Given this list of marker genes Git1, Grin3a, Ppp1r13l, Ahr (aryl-hydrocarbon receptor), Mir7578, Angpt2, Nbl1, Foxp3, Inpp5f, Pcbp2, Sh2d1b1, Igf1, Sh2d1b2, Wnt5a, Cers2, Ilrun, Clec12a, Il4, Mvk, Stat3, Fpr-rs7, Slit1, Plxna3, Clec12b, Ifi209, Rtn4rl1, Tyro3, Cask, Stap1, Trib1, Serpinb9e, Mir147, Phldb2, Gstp1, Eif4e2, Cacnb3, C5ar2, Lgals9, Ctnna2, Irgm1, Tnfaip3 (tumor necrosis factor, alpha-induced protein 3), Hamp, Spn, Ifi206, Siglecg, Grid2, Nfkbil1, Inpp5d, Rtn4r, Drd4, Adtrp, Nr1d2, Ythdf3, Fam3a, Ifi203-ps, Ier3, Robo1, Sirpa, H2-T23, Stat2, Drd1, Cpb2 (NCBI Gene Id 93820), Mmrn1, Nlrc5, Slit2, Ptger4, Plau, Adar, Mkrn2, Oas1f, Ghrl, Nfkb1, Dusp10, Cldn19, Dhx58, Mndal, F11, Grin1 (glutamate receptor, ionotropic, NMDA1 (zeta 1)), Tmprss6, Ajap1, Nlrp12, Nlrp4a, Padi2, Serpinb9, Isl1, Oas1e, Nr1h2, Tspan8, Acp5, Fgg, Aif1, Mmp28, Lpcat3, Ucn, Gigyf2, Tafa5, Oas3, Nectin2, Rtca, Ddx39a, Muc19, Mefv, Fabp7, Irgm2, Pla2g10, Kremen1, Mmp12, Tnf, Nt5e, Tarbp2, Mul1, Siglece, Kng2, Apoe, Ifi203, Ptprs, Hrg, Tnfrsf1b, Sema3f, Il22 (interleukin 22), Il22ra2, Arg1, Usp38, Abr, Il10, Serpinf2, Ash1l, Il33, Usp15, Ceacam1, Aoah, Dnaja3, Adipoq, Ccr1, Arg2, Fgl2, Pten, F12, Rin3, Il20rb, Ttll12, Tnfrsf1a, Fam76b, Tff2, Serpinb9d, Nlgn3, Il22b, Mdga1, Foxf1, Usp18, Prkcd, Nrp1, Plaur, Cd200, Nrxn1, Trim65, Dtx4, Nr1d1, Rgma, C1qtnf12, Fem1a, Alox12, Hgf, Grn, Socs5, Ada, Oas1g, D130043K22Rik, Slc6a3, Sema3a, Ets1, Cnot7, Traf3ip1, Klre1, Fpr-rs4, Banf1, Dpp4 (NCBI Gene Id 13482), Muc16, Irak3, Cx3cl1, Nr1h4, Defb21, Rb1, Serpinb9c, Gpx2 (glutathione peroxidase 2), Igf2, Klrb1b, Alox5, Reg3a, Clec2d, Cd96, Trafd1, Pdgfra, Cldn3, Drd2, Ins2, Ptpn2, Ins1, Cxcl17, Ifi214, Ndfip1, Clasp2, Psmb4, Ctla2a, Cx3cr1, H2-M3, Anxa2, Ghsr, Pbk, Sh2b3, Ythdf2, Ptgr1, Il17a, Slc12a2, Mill1, Pros1, Isg15, Ppm1b, Ifi208, Il13, Ubash3b, Clasp1, Lyar, Pdgfa, Lrig2, Slamf8, Extl3, Trim21, Cd276, Nr5a2, Prdx2, Adamts18, Sema5a, Mfhas1, Nt5c2, Dcst1, Krt1, Serping1, Sfn, Tmsb4x, Metrnl, Aph1b, Pdgfb, Dsg2, Gpr18, Fndc4, Sbno1, Arrb2, Bace1, Zfp36, Samhd1, Proc, Dusp3, Gstp2, Coro1b, Kng1, Selenos, Il2, Fpr-rs6, Cyld, Acod1, Hdac6, Cd200l2, A2m, Bcr, Cd44, Igtp, Chrna7, Mapkbp1, Nlrp3, Oas1b, Oas1d, Enpp3, C1qtnf1, Grb2, Dvl1, Syt11, Nlrc3, Cd9, Nlrx1, Tafa3, Tap1, Fxr1, Il10ra, Cd109, Ppara, Cxcl13, Nr1h5, Gfer, Dbn1, Mif, Pf4, Plg, Adora2a, Dusp1 (dual specificity phosphatase 1), Elf4, Adora1, Adcyap1 (adenylate cyclase activating polypeptide 1), C1qtnf3, Anxa5, Il22ra1, Klkb1, Il2ra, Epha4, Rabgef1, Klrk1, Fem1al, Sod1 (NCBI Gene Id 319325), Uaca, Nlrp4b, Cd200l1, Fpr2, Ifi213, Cst7, Ltf, Serpine2, Il12b, Mavs, Oas1h, Cdh5, Otulin, Trim45, Fcgr2b, Thbs1, Serpinb9h, Oas1c, Tgfb1, Rps19, Ppard, Tmx1, Havcr2 (hepatitis A virus cellular receptor 2), Sharpin, Fgb, Trem2, Xylt1, Serpinb9f, Gp5, Gata3, Eppk1, Htra1, Vsig4, Zdhhc18, Parp1, Wfdc1, Trim38, Rnf26, Myoz1, Smpdl3b, St6gal1, Arnt, Atg5, Rora, Nmi, Vtn (NCBI Gene Id 22370), Nr1h3, Ccn3, Rnf26rt, Crk, Ptpn6 (protein tyrosine phosphatase, non-receptor type 6), Hc, Vps35, Reg3g, Ldlr, Serpinb9g, Trex1, Robo2, Npy, Aph1c, Npy5r, Nlrp6, Gps2, Gpx1, Atg12, Fgf2, Gper1, C1qbp, Nlrp4c, Tfpi, Tnfaip8l2, Itch, Ywhaz, Prkg1, Cd24a, Tnr, Pglyrp1, Pparg, Nlrp4e, Plat, Lrfn5, Tnfaip6, Apoa1, Serpinb9b, Drd3, Ccl12, Thbd (thrombomodulin), Nod2, Chd8, Smim30, Ffar4, Pdcd10, Susd4, Notch1, Psma1, Mettl3, Cep63, Oas1a, Parp14, F2, Cyp19a1 (NCBI Gene Id 13075), Psg23, Otop1, Cd200r1, Wnt3, Wnt3a, Nectin4, Slc39a8 (solute carrier family 39 (metal ion transporter), member 8), Apoh, Smad3, Cactin, Aurkb, Ifnb1, Wnt4 (wingless-type MMTV integration site family, member 4), Tap2, Ptgis, Pla2g5, Fga, Ifi207, Macir, Nlrp4f, Neo1, Grem1, Serpine1, Mdk, Fpr-rs3, Pim1, Gp1ba, Tpsab1, Socs3, Gpr17, Gpr31b, Klrd1, Ryk, here is a description of the gene set: Mouse Gene Set: GOBP_NEGATIVE_REGULATION_OF_RESPONSE_TO_EXTERNAL_STIMULUS species: Mus musculus Any process that stops, prevents, or reduces the frequency, rate or extent of a response to an external stimulus.